The following is a description of a gene set: from publication Peltier DC, Simms A, Farmer JR, Miller DJ (PMID 20483728) Human neuronal differentiation alters responsiveness to innate immune stimuli and virus infections. We used microarrays to examine the transcriptional responses of the human BE(2)-C neuroblastoma cell line to retinoic acid-induced differentiation and type I IFN stimulation. Human Gene Set: GSE16450_CTRL_VS_IFNA_6H_STIM_MATURE_NEURON_CELL_LINE_UP studied in species Homo sapiens Genes up-regulated in mature neuron cell line: control versus interferon alpha (6h)., and this is the list of marker genes: IKZF4, LRP1B, FUT7, ADAMTS19, MDGA2, ZNRF1, PPP1R3F, TP53I11, PADI4, DTX3L, PFN2 (profilin 2), GPR182, GM2A (ganglioside GM2 activator), PTGS1, VEGFC, GABBR1, PIANP, CORO7, RAB11FIP2, RAB3A, CTLA4 (NCBI Gene Id 3411), PLAC8, NWD2, KAT2B, TPCN1, BTBD2, ANO1, KCNQ4, CORO2A, TAFA3, HLA-DOB, CPB2, PPM1L, CTNND1 (catenin delta 1), ZDHHC8 (zinc finger DHHC-type palmitoyltransferase 8), TXK, NTM, DUSP8, SYTL1, NEUROD4, GBP7, GLYAT, NT5DC3 (5'-nucleotidase domain containing 3), ITGAE, ATP1A4, LRRC8C, OIT3, SGK1, KLHL26, ZP2, RIMS3, WLS, ZNF608, RASGEF1A, ST8SIA4, APOBR, TNS1, B3GNT5, HYKK, CD86, ENTREP3, PSMA8, PVALB, GCK, SLC14A1, TMEM80, RIMBP2, MEF2D, B3GALT1, NETO1, GRHL3, A1CF, DLG4, RNASE4, TCF7L1, NCCRP1, ABCA4, FAM174B, SSH1, RGL2, TFAP2D, ITIH5, SLC26A5, IL17RE, TOP3B, RNASEL, FBN1, ICOS, RTP4, PIK3R1, MTMR3, MEDAG, HECTD3, TXNIP, AKR1C4, KCND2, PRNP (prion protein (Kanno blood group)), CWH43, IKZF2, NIPAL1, SLC22A8 (solute carrier family 22 member 8), DBP, FGG (NCBI Gene Id 2266), NDRG1, SOCS3, IGSF1, TMEM25, SYP, NRP1, TSC22D4, CD34, SOCS2, CHD3, KLKB1, PRKD3, MGST2, INPP5K, LGI1, SWAP70, PANX3, MICALL1, INSC, KLRG1, TBC1D14, PRDM2, PTPN13, TIAM1, MB, PHC3, MXD1, KCNH2, GPR83, KDSR, TBC1D20, SERTAD4BP, FBLN2, TMCC3, IL2RA, SPDYA, LRRN2, CCS, ECM1, TMOD4, DDX60, TRAF3IP1, SELP, RRAGD, PRG3, NOX4, TRPA1, GATA1, C19orf12, ITM2C, AHCYL2, PDE6H, ADAM11 (ADAM metallopeptidase domain 11), EIF4E3, TMEM91, CCR2 (NCBI Gene Id 90262), TMEM164, RCN1, CA10, KRT5, FAT4, TBC1D30, TAS1R3, MRAP, GPX6, RCAN3, CYP4F3, MMP2, NRP2, IGFLR1, CD1D, GOLGA7B, COG8, SYT4, HIPK2, GLRA4, STMND1, TECPR1, PHLPP1, KLK11, DLX4, SH3RF3, SLITRK1, DRC1, RANBP6, C3orf70, CYBB, NT5E, IL17RB, SPOCK2, CPE, RGS14, IL18R1, CNDP2, IFNLR1, ARMC9